Given this list of marker genes Bco2, Apoa4, Agrn, Apob, Bco1, Akr1c21, Ttpa, Apoa1, Vkorc1, Gpc3, Lpl, Sdc4, Lrp12, Pnlip, Clps, Apoc2, Gpc6 (glypican 6), Akr1c20, Ttr, Apoe, Apoc2l, Gpc1 (NCBI Gene Id 98368), Rbp4, Plb1, Lrp1, Vkorc1l1, Lrat, Ubiad1, Rdh11, Gpc5, Sdc1, Rbp1, Lrp8, Gpihbp1 (GPI-anchored HDL-binding protein 1), Rbp2, Apom, Akr1b10, Lrp2, Sdc2 (NCBI Gene Id 74599), Gpc4, Akr1c6, Gpc2, Apoa2, Sdc3, Lrp10, here is a description of the gene set: species: Mus musculus Metabolism of fat-soluble vitamins Mouse Gene Set: REACTOME_METABOLISM_OF_FAT_SOLUBLE_VITAMINS